Given this list of marker genes DYNC2I2, SLC26A2, LBR, COL2A1, DYNC2H1, DYNC2I1 (NCBI Gene Id 55112), WDR35, TRIP11, PTH1R, IFT80, here is a description of the gene set: Lethal skeletal dysplasia studied in species Homo sapiens Human Gene Set: HP_LETHAL_SKELETAL_DYSPLASIA